The following is a description of a gene set: A separation (dissection) of the layers of an artery. species: Homo sapiens Human Gene Set: HP_ARTERIAL_DISSECTION Arterial dissection, and this is the list of marker genes: PLOD1, COL5A2, TGFBR1, TGFBR2, COL1A1, IPO8, TGFB2, COL3A1, SMAD2, SMAD3, COL5A1, TGFB3